The following is a description of a gene set: Transport of nucleotide sugars studied in species Mus musculus Mouse Gene Set: REACTOME_TRANSPORT_OF_NUCLEOTIDE_SUGARS, and this is the list of marker genes: Slc35a1, Slc35d2, Slc35c1, Slc35b4, Slc35b2, Slc35a3, Slc35a2, Slc35b3, Slc35d1